The following is a description of a gene set: studied in species Mus musculus A neuron projection that is found in unipolar neurons and corresponds to the region between the cell body and the point at which the single projection branches. Mouse Gene Set: GOCC_CELL_BODY_FIBER, and this is the list of marker genes: Srd5a2, Sptbn4, Crhr2, Ass1, Penk, Asl, Kcnj11, Srd5a1, Htr2a, Apc